The following is a description of a gene set: Reactome Pathway: DAG1 core M3 glycosylations part of: DAG1 glycosylations Core M3 glycans are initiated by beta-1,4-linked GlcNAc extension of O-mannose and always contain the trisaccharide linker glycan GalNAc-GlcNAc-ManP bound to O-threonines of the core protein. The only glycan known to be bound to Core M3 is matriglycan, a glycosaminoglycan (GAG)-like polysaccharide consisting of a long linear chain of repeating heterodisaccharide and two ribitolphosphate subunits. species: Homo sapiens, and this is the list of marker genes: POMT2, POMT1, B3GALNT2, POMGNT2, POMK, DAG1